The following is a description of a gene set: Human Gene Set: LI_PBMC_ZOSTAVAX_AGE_25_40_AND_60_79YO_1DY_UP Herpes zoster (shingles) causes significant morbidity in immune compromised hosts and older adults. Whereas a vaccine is available for prevention of shingles, its efficacy declines with age. To help to understand the mechanisms driving vaccinal responses, we constructed a multiscale, multifactorial response network (MMRN) of immunity in healthy young and older adults immunized with the live attenuated shingles vaccine Zostavax. Vaccination induces robust antigen-specific antibody, plasmablasts, and CD4<sup>+</sup> T cells yet limited CD8<sup>+</sup> T cell and antiviral responses. The MMRN reveals striking associations between orthogonal datasets, such as transcriptomic and metabolomics signatures, cell populations, and cytokine levels, and identifies immune and metabolic correlates of vaccine immunity. Networks associated with inositol phosphate, glycerophospholipids, and sterol metabolism are tightly coupled with immunity. Critically, the sterol regulatory binding protein 1 and its targets are key integrators of antibody and T follicular cell responses. Our approach is broadly applicable to study human immunity and can help to identify predictors of efficacy as well as mechanisms controlling immunity to vaccination. from publication Li S, Sullivan NL, Rouphael N, Yu T, Banton S, Maddur MS, McCausland M, Chiu C, Canniff J, Dubey S, Liu K, Tran V, Hagan T, Duraisingham S, Wieland A, Mehta AK, Whitaker JA, Subramaniam S, Jones DP, Sette A, Vora K, Weinberg A, Mulligan MJ, Nakaya HI, Levin M, Ahmed R, Pulendran B (PMID 28502771) Genes up-regulated in peripheral blood mononuclear cell 1d vs 0d in adults (25-40/60-79) after exposure to Zostavax, time point 1D species: Homo sapiens, and this is the list of marker genes: PSPH, CCL5, SLC22A16, GZMH, MYO6, S1PR5, TARP